Given this list of marker genes TEFM, ATXN2, ERCC1, CSF1R, PPFIBP1, GALC, PPP1R15B, PIGG, PDYN, MRPL39, ASPA, CYP27A1, L2HGDH, PSAP, LRPPRC, ACOX1, PRF1, ERCC8, NDUFAF4, RERE, MMACHC, SUMF1, ADAT3, PYCR2, MAT1A, MTTP, ABCD1, ERCC6, INSR, PRPS1, HTRA1, HLA-DQB1, PEX19, TREM2, TRMT10A, HLA-DRB1, GFAP, TREX1, TNR, GLS, ALDH3A2, EIF2B1, here is a description of the gene set: CNS demyelination species: Homo sapiens Human Gene Set: HP_CNS_DEMYELINATION A loss of myelin from nerve fibers in the central nervous system.